The following is a description of a gene set: Human Gene Set: GOBP_ADIPOSE_TISSUE_DEVELOPMENT The process whose specific outcome is the progression of adipose tissue over time, from its formation to the mature structure. Adipose tissue is specialized tissue that is used to store fat. species: Homo sapiens, and this is the list of marker genes: HMGA2, SELENOM, PIK3CA, GHRL, ARRDC3, HMGCS2, GUCA2B, ASNSD1, PAXIP1, SOX8, NCOA1, PPARD, COL6A1, PARP1, RASAL2, SH3PXD2B, PRKAA1, SLC25A25, BBS4, ZNF516, PPARG, DGAT2, CD2AP, ATF2, SIRT1, ID2, UMODL1, CASR, LIPA, AMER1, KLF7, LRP5, SPTLC2 (serine palmitoyltransferase long chain base subunit 2), TBL1XR1, CSF1, OXCT1, ACAT1, IFRD2, LPL, NAMPT, HRAS, DYRK1B, ABHD15, MIR138-1, VPS13B, RORC, FAM83A, ERRFI1, PLAAT3, FOSL2, GPR82, UBB, PUM2, ARID5B, EBF2, SPART, POU4F2, IFRD1, XBP1, SORL1, NR1H4, TRPM4, INHBE, PPARGC1A, PGRMC2, NCOA2, HSD17B1, FTO, SPI1, LEP